Given this list of marker genes Cmya5, Tnni1, Tead1, Gtf2ird2, Mymk, Igfbp5, Tnnc1, Mtor (NCBI Gene Id 80612), Atp2a2, Actn3, Tnnt1, Ppp3ca, Nfatc1, Myh7, Gtf2ird1, here is a description of the gene set: species: Mus musculus Mouse Gene Set: GOBP_REGULATION_OF_SKELETAL_MUSCLE_ADAPTATION Any process in which skeletal muscle adapts, with consequent modifications to structural and/or functional phenotypes, in response to a stimulus. Stimuli include contractile activity, loading conditions, substrate supply, and environmental factors. These adaptive events occur in both muscle fibers and associated structures (motoneurons and capillaries), and they involve alterations in regulatory mechanisms, contractile properties and metabolic capacities.